Given this list of marker genes Il18, Igfbp2, Cd46, Pnp, Cd209d, Ccl19, Stat5a, Ccl5, Il21, Il1a (interleukin 1 alpha), Hmgb1, Bmi1, Nckap1l, Tnfsf9 (NCBI Gene Id 21950), Havcr2, Cd24a (CD24a antigen), Syk, Zap70, Rps3, Xcl1, Ccr7, Jak3, Cd244a, Cd1d1, Tfrc, Cd209c, Icosl, Efnb1, Cd209e, Btnl2, Zp3, Il4, Slc4a1, Tnfrsf13c, Ptprc, Nr5a2, Carmil2, Rasal3, Slamf1, Lep, Il6st (NCBI Gene Id 71317), Vtcn1, Il12b, Il12a (interleukin 12a), Ccr2, H2-DMb1, H2-DMb2, Prkcq, Kitl, Coro1a, Nck1, Cd80, Pycard, Tyk2, Dhps, Il23a, Cd3e, Il1b, Cd86, Spta1, Fadd, Cd1d2, Igf2, Tnfsf13b (tumor necrosis factor (ligand) superfamily, member 13b), Irgm1, Il6, Il2, Il12rb1, Cd59a, Selenok, Ppp3ca, Ptpn22, Pdcd1lg2, Stat5b, Cd4, Shh, Cd55b (CD55 molecule, decay accelerating factor for complement B), Nck2, Hes1, Il15, Epo, Foxp3, Cd6, Tgfbr2, Il3, Vcam1, Cd276, Cd59b (CD59b antigen), Ccdc88b, Igf1, Blm, Cd81, Cd274, Anxa1, Adk, Cd55 (NCBI Gene Id 13136), Cd40lg, Tnfsf4, Dnaja3, Il2ra, Itgal, Traf6, Card11, Slc7a1 (solute carrier family 7 (cationic amino acid transporter, y+ system), member 1), Ager, Ripk2, Cd28, Ifng, Jak2, Spn, Sash3, Gpam, H2-T23, Aif1, here is a description of the gene set: Mouse Gene Set: GOBP_POSITIVE_REGULATION_OF_T_CELL_PROLIFERATION Any process that activates or increases the rate or extent of T cell proliferation. studied in species Mus musculus